The following is a description of a gene set: from publication Figueroa ME, Lugthart S, Li Y, Erpelinck-Verschueren C, Deng X, Christos PJ, Schifano E, Booth J, van Putten W, Skrabanek L, Campagne F, Mazumdar M, Greally JM, Valk PJ, Löwenberg B, Delwel R, Melnick A (PMID 20060365) Cluster 3 of aberrantly hypermethylated genes in blasts from AML (acute myeloid leukemia) patients. Human Gene Set: FIGUEROA_AML_METHYLATION_CLUSTER_3_UP studied in species Homo sapiens We hypothesized that DNA methylation distributes into specific patterns in cancer cells, which reflect critical biological differences. We therefore examined the methylation profiles of 344 patients with acute myeloid leukemia (AML). Clustering of these patients by methylation data segregated patients into 16 groups. Five of these groups defined new AML subtypes that shared no other known feature. In addition, DNA methylation profiles segregated patients with CEBPA aberrations from other subtypes of leukemia, defined four epigenetically distinct forms of AML with NPM1 mutations, and showed that established AML1-ETO, CBFb-MYH11, and PML-RARA leukemia entities are associated with specific methylation profiles. We report a 15 gene methylation classifier predictive of overall survival in an independent patient cohort (p < 0.001, adjusted for known covariates)., and this is the list of marker genes: ZNF875, PDHX, CNTROB, BCL7A, ZNF281, MATR3, ELAVL2, RSKR, GSN-AS1, ZFR, COCH, TIGD3, GUCY1B1, DPYSL4, ZNF662, APIP, TLR2, ZNF667, DYNC1LI1, ZSCAN1, ZNF264, PRR18 (NCBI Gene Id 285800), ZNF501, MAD1L1, GPAT4, RECQL5, PAQR5, ZNF154, FSTL1, POU3F4, CDK8, ZNF343, GLIPR1L2, NIT1, NNAT, ZNF560, TUBB6, MAP7D3, SLC8A3, SLC39A14, PCDHA11, PCDHB8, SMAD3, YBX3, ZNF582, TAFA4, KNSTRN, MSRB3, THBS4, MOS, TAF3, EREG, TEK, SLC66A1LP, BTAF1, PABPN1, LHCGR, POU5F1, HNRNPD, COL21A1, PLPBP, PRRG1, CAPS2, EXOSC2, GPR149, PCDHB16, LEMD2, THEM4, LBX2, TRAPPC1, KRTCAP3, OXA1L, NTN5, MAP7, PCDHGB7, BLOC1S1, BTBD3, HNF4A, RIPPLY3, TNFAIP8L2, SLC9A8, MKKS, TGFBR1, ABLIM1, CASP2, AGO1 (argonaute RISC component 1), TIE1, CRHBP, PCDHB9, ZIC5, UHRF1, IDH3B, CUL9, TANC2, GTF3C1, TMEM263, DHRS12, YTHDF2, HMCES, NFIX, FAM83B, ISCA1, SMIM15, C3orf38, TNPO3, IPO8, CEP41, PCDHGB4, ZFP3, GTF2A1, GPRASP3, PCDHB11, SPOP, PYGO1, BPGM, CALCOCO1, KCNAB3, NRP2, VWA5A, PPP2CA, PCDHB18P, PFN2, ZBTB45, DNM3, CDX4 (NCBI Gene Id 1046, caudal type homeobox 4), ZNF84, PACRGL, STX18, GJB6, PCDHGA5, SLX4IP, PIAS2, PIGZ, NEUROG1, PCDHB10, SCG5, AMOTL1, KATNIP, MT2A, ZBTB14, IL11RA, PCDHGA8, TBC1D31, CANT1, PCDHB14, REXO2, SLC25A51, N4BP1, KRT81, CYP26C1 (NCBI Gene Id 340665), ADGRG6, ARHGAP44, EXOSC3, ARAF, GLRA1, PCDHB17P, HILPDA, CCDC34, GAN, SAP30BP, PFDN2, PCDHGA11, CHCHD2, NIM1K, ZFP28, ZFHX2, MYL4, MCTS1, PMAIP1, VWF